Given this list of marker genes Nfkbiz, Lrp6, Gpx1 (NCBI Gene Id 14775), Ogg1, Folr1 (folate receptor alpha), Ascl1, Folr2, Tyms, Cbs, Bche, here is a description of the gene set: Any process that results in a change in state or activity of a cell or an organism (in terms of movement, secretion, enzyme production, gene expression, etc.) as a result of a folic acid stimulus. Mouse Gene Set: GOBP_RESPONSE_TO_FOLIC_ACID studied in species Mus musculus